The following is a description of a gene set: part of: Mitotic G1 phase and G1/S transition species: Homo sapiens Reactome Pathway: G1 Phase Early cell cycle progression in G1 is under the control of the D-type cyclins together with Cdk4 and Cdk6. An important target for these CDKs is the Retinoblastoma (Rb) protein, which when phosphorylated promotes cell cycle progression by releasing E2F transcription factors that transactivate several important genes for later cell cycle events. The formation of Cyclin D - Cdk4/6 complexes is promoted by two proteins, p21Cip1/Waf1 and p27kip1, and their activity can be inhibited by the binding of several small CDK-inhibitory proteins (CKIs): p15INK4B, p16INK4A, p18INK4C and p19INK4D., and this is the list of marker genes: E2F3, PPP2CA (NCBI Gene Id 5515), UBB, JAK2, CDKN1B, CCND2, CDK7, LYN, SKP1, SKP2, TFDP2, PTK6, MNAT1, E2F2, UBC, CDK2, CDKN2B, CDKN1C, RBL1, CCND1, TFDP1, CCNE2, SRC, E2F1, CCND3, CDKN2C, RBL2, PPP2R3B, UBA52, ABL1, CCNH (NCBI Gene Id 902), PPP2CB, PPP2R2A, CDKN2A, RPS27A, CDKN1A, E2F5, PPP2R1A, CCNE1, CKS1B, RB1, CDKN2D, CDK4, CDK6, CUL1, PPP2R1B, E2F4